Given this list of marker genes Tnfsf4, Supt6, Msh2, Ifng, Hspd1, Exosc3, Trex1, Mir181b-1, Shld3, Ccr6, Hmces, Foxp3, Il2, Pcyt1a (NCBI Gene Id 13026), Slc15a4, Gapt, Trp53bp1, Ercc1, Il4, Stat6 (NCBI Gene Id 216450), Exo1, Atad5, Nsd2, Cd40lg, Mir181b-2, 6030468B19Rik, Rif1, Paxip1, Aplf, Ptprc, Lig4, Nod2, Exosc6, Traf3ip2, Parp3, Crlf2, Tnfsf13, Shld2, Mad2l2, Enpp1, Xrcc4, Ighm, Msh6, Gcnt3, Tgfb1, Kmt5c, Cd28, Fgl2, Btk, Icosl, Clcf1, Tfrc, Swap70, BC037156, Rnf168, Sanbr, Ung, Bcl6, Rnf8, Pagr1a, Shld1, Mlh1, Il27ra, Nbn, Aicda, Batf, Cd40, Pou2f2, Xcl1, Pms2, Ndfip1, Kmt5b, Tbx21, Nfkbiz, here is a description of the gene set: Mouse Gene Set: GOBP_IMMUNOGLOBULIN_PRODUCTION_INVOLVED_IN_IMMUNOGLOBULIN_MEDIATED_IMMUNE_RESPONSE The appearance of immunoglobulin due to biosynthesis or secretion following a cellular stimulus during an immune response, resulting in an increase in its intracellular or extracellular levels. studied in species Mus musculus